The following is a description of a gene set: The gene expression program underlying the specification of human cell types is of fundamental interest. The study authors generated human cell atlases of gene expression and chromatin accessibility in fetal tissues. For gene expression, the study authors applied three-level combinatorial indexing to >110 samples representing 15 organs, ultimately profiling ~4 million single cells. The study authors leveraged the literature and other atlases to identify and annotate hundreds of cell types and subtypes, both within and across tissues. Our analyses focused on organ-specific specializations of broadly distributed cell types (such as blood, endothelial, and epithelial), sites of fetal erythropoiesis (which notably included the adrenal gland), and integration with mouse developmental atlases (such as conserved specification of blood cells). These data represent a rich resource for the exploration of in vivo human gene expression in diverse tissues and cell types. from publication Cao J, O'Day DR, Pliner HA, Kingsley PD, Deng M, Daza RM, Zager MA, Aldinger KA, Blecher-Gonen R, Zhang F, Spielmann M, Palis J, Doherty D, Steemers FJ, Glass IA, Trapnell C, Shendure J (PMID 33184181) Human Gene Set: DESCARTES_FETAL_STOMACH_NEUROENDOCRINE_CELLS species: Homo sapiens Marker genes curated from the annotated cluster as represented in the Descartes Human Gene Expression During Development database., and this is the list of marker genes: NEUROD1, SST, GHRL, NPSR1-AS1 (NPSR1 antisense RNA 1), KCNH6, HAP1, SEC11C, MAOB, FRMPD4, NKX2-2, PTF1A, ROS1, DPEP1, GAST, CRYBA2, HDC, SYT13, ST18, RFX6, KCNH7, DEPP1, PTH2R, SLC38A11, MEGF11, LINC02532, PPY, VWA5B2, CACNA1A, RBPJL, RGS4, CDK5R2, PAX6, GCK, DNAJC12, TTR, PCSK1, LHX5-AS1, HS3ST4, TPH1, FEV, RFX4, AP3B2, CHGA, MBOAT4, GC, SLC18A1 (solute carrier family 18 member A1), LINC00261, LINC00907 (long intergenic non-protein coding RNA 907), GCG, GHRLOS